Given this list of marker genes LILRA2, LGR4, BCL2, NINJ1, PTPN22, NFKBID, ZCCHC3, REG3G, NLRP2B, IFI35, GBP5, CLPB, LILRB4, GDI1, KIR2DS2, BTK, TLR4, CGAS, CD2AP, VSTM1, IFIH1, IGHG3, IRAK4, PIK3R1 (NCBI Gene Id 5295), ZAP70, RTN4, CD300A, NMI, IRF4, IGLC6, FCRL3, SLC39A10, KLHL6, BTNL2, CD274, KIR2DS3, FCHO1, EPG5, KCNN4, PTPN2, GPLD1, IRF5, TLR6, UBASH3A, IGSF1, ABL1, CRKL, BTN2A2, RBCK1, SYK, TNF, SPPL3, HSPA1A, CD47, CACNB3, COLEC11, MAVS, NFKBIA, NFATC2, CD24, OGT, CD300LB, CD28, PTPN6 (NCBI Gene Id 5777), CCR7, COLEC12, CSNK1A1, XIAP, PYDC1, MAP3K1 (mitogen-activated protein kinase kinase kinase 1), AKT1 (AKT serine/threonine kinase 1), TAX1BP1, KIR2DS4, TRIM11, ITPRIPL1, SRC, FCGR3A, CLEC7A, IRAK1, LYN, MIR34A, LAMP2, LTF, DGKZ, TLR8, DDX41, HMGB1, MNDA, EIF2B3, OSCAR, TNIP1, NOS2, ZDHHC1, BLNK, RELA, CD33, PAK2, FOXP3, NLRP1, KIR2DL4, IGHD, ELF1, SMPDL3B, SLC15A4, FOSL2, TIFA, FER, KLRC2, PAK1, CD19, LILRA6, SARM1, LAIR2, PYCARD, WASHC4, CLEC12B, PPP6C, NECTIN2, LAX1, LATS2, TYRO3, BCAR1, CD79B, CTLA4, HLA-A, LAT2, DENND1B, C5AR1, NPLOC4, MOG, LRRC19, TICAM1, CD8A, LILRB3, PRKCD, BTNL10P, EIF2AK2, CR1, FBXL2 (F-box and leucine rich repeat protein 2), AURKB, TRIM3, FPR1, STAP1, MAPK8, HDAC6, FLOT2, TRBC2, IFNG, FCGR2A, CD22, RAB7B, NLRX1, RFTN1, DUSP22, LAIR1, C3, PUM1, HLA-G, NAGK, FCER2, THEMIS, TMIGD3, DDX3X, IRGM, TLR9 (NCBI Gene Id 54106), GPR32, CYBA, MS4A1, YWHAE, TRAF6, MAPKAPK3, HSPA8, PAK3, NOD1, THY1, BTLA, HCFC2, KIR2DL3, PUM2, LIMK1, PIGR, KIR3DX1 (NCBI Gene Id 90011), CD226, CD247, NFKB1, TRAF3, ERMAP, RNF144A, BANK1, LILRA5, VAV1, NLRP3, LILRA1, NR1H3, TRGC1, MARCHF5, APP, MAP3K7, MAPK10, FCN1, KLRC4-KLRK1, TKFC, SPSB3, DHX33, IGHA2, KLRD1, NLRC4, IL20RB, BTN3A1, BRAF, ELP6, CD72, ESR1, KLRK1 (NCBI Gene Id 22914), VAV3, TLR1, TLR3, RNF170, TIRAP (TIR domain containing adaptor protein), KIR2DL5B, IRF3 (interferon regulatory factor 3), TLR10, P2RX7, NLRC3, LRRC14, KLRC1, BTN2A1, GCSAML, TLR7, FCMR, TRGC2, KIR3DL1, PSEN1, BTNL9, IRF1, APPL2, FCGR1BP, FGR, GKN2, FCGR1A, SH2B2, PRKCQ, ZNRF1, SPG21 (SPG21 abhydrolase domain containing, maspardin), BIRC3, MYD88 (NCBI Gene Id 4615), BPIFB1, KIR2DL1, MARK4, TREX1, CLEC4D, MIR146A, TNFAIP3, FCN2, MIR149, PLD2, LILRA3, MEF2C, SCARA3, GPR33, MIR17, DHX58, FCER1G, NEK7, PLCG2, PLA2G6, DAB2IP, TLR2, KIR2DL5A, ZC3H12A, HSPA1B, LIPA, LRCH4, IRAK2, BTNL8, ATAT1, TRIM31 (tripartite motif containing 31), S100A8, MAPK1, LIME1, PCBP2, RNF31, NOP53, A1BG, KIR3DL3, SOS1, NCKAP1L, CPTP, TYROBP, SCIMP, RSAD2, IGKC, CCDC134, OAS3, IGHG1 (immunoglobulin heavy constant gamma 1 (G1m marker)), CD79A, LILRB2, CD8B, PRKCE, FCGR3B, RIGI, KIR3DL2, RABGEF1, PTPRS, PRKD2, S100A14, FCAR, TASL, LGALS3, CARD11, HCK, GPS2, IKBKB, HSP90B1, TEC, CD36, CD276, PDE4B (NCBI Gene Id 5142), PLCL2, S100A9, RIPK2, UBR2, EIF2B2, MIR200B, RNF125, TRIM25, CACNB4, C5AR2, ANKRD17, PHPT1, PLSCR1, NAIP, UFD1, NR4A3, PPP2CA, TBK1, MAP2K4, MYO1G, OASL, LSM14A, TRIL, ITCH, BMX, UBE2N, PRNP, SKAP1, KCNK13, NCR3, RGCC, KLRC4, MIR20A, BANF1, MIR210, KIT, EP300, TRIM32, FLOT1, UNC93B1, LAPTM5, HLA-DRB3 (major histocompatibility complex, class II, DR beta 3), IRAK3, CD200R1, ZDHHC5, KIR2DS1, SMPDL3A, TMEM126A, FCGR2C, SEC14L1, LILRB1, PTK2, RAP1A (RAP1A, member of RAS oncogene family), TESPA1, WDFY1, GCSAM, RAB29 (NCBI Gene Id 8934), RC3H2, STMP1, MIR18A, PELI1, OAS1, HLA-DRB1, ABHD8, CD300LF, MEFV, RNF34, LCP2, C1QBP, INAVA, CEACAM1, MIR140, USP15, PDPK1, STK11, LILRA4, CD38, CACTIN, FYB1, ZDHHC18, GPR32P1, ZC3HAV1, NR1H4, PARP1, NFKBIZ, FFAR2 (free fatty acid receptor 2), STOML2, KIR3DS1 (NCBI Gene Id 3813), BIRC2, GRAMD4, SLC15A2, MALT1, DDX60, DUSP3, TNFRSF21, IGHG2, IKBKG, WNK1 (NCBI Gene Id 9872), KIR2DL2, PLPP4, F2RL1, PRKCB, AIM2, KHDRBS1, PYDC2, GP6, RNF39, ALPK1, EZR, BTN1A1, C3AR1, KCNK6, TRAT1, IGHA1, IGLC7, ITK, MBL2, ARRB2, AP3B1, PHB2, EIF2B5, PRKD1, INPP5D, HAVCR2 (NCBI Gene Id 84868), VAV2, SLA2, FPR2, TRBC1, BTN3A3, COLEC10, KCNJ8, CD300LD, LGALS9, BRCC3, IGLC3, MFHAS1, ABHD17A, PTPRJ, LCK, CLEC4E, BAG6, NFAM1, PLEKHA1, ZDHHC12, LBP, SLC46A2, ZDHHC9, CD160, CTSH, FYB2, TRIM15, LYPLAL1, CD40, CASP1, TLR5, CREBBP, CYLD, PPT1, CD3G, CTSS, PSG9, LETMD1, PHB1, NAGLU, SLC39A6, CD14, TRAC, TXK, SLC19A1, MIR4691, TNIP3 (NCBI Gene Id 79931), FOXP1, NCK1, PIK3AP1, HRAS, HHLA2, PDE4D, SHB, NFKBIL1, IGHG4, MAP2K6, IRF7, EIF2B4, SIVA1, HLA-DPB1, THEMIS2, MIR19A, TREML4, IGHM (NCBI Gene Id 3507), PLCG1, GBP2, GFI1, ZNF683, GATA3, BCL10, PJA2, CD3D, ACOD1, UBQLN1, PIK3CA, TRDC, CLEC6A, HSPD1, RNF115, RNF135, OTULIN, LACC1, SLC15A3, CD3E, PVRIG, TRIM65, LATS1, TREM2, MAPK9, YES1, ADA, ERBIN, CSK, TARBP2, NLRP6, TNIP2, FCN3, ZNRF4 (NCBI Gene Id 148066), SQSTM1, TIFAB, KIR2DS5, MIR708, PTPRC, CMTM3, TAB1, LILRB5, NOD2, PRKDC, FOSL1, PIK3CD, CHUK, GPR108, IPO5, NR1D1, LPXN, GPATCH3, MAPKAPK2, MAP2K7, IFI16, AARS2, PYDC5, TRAF3IP3, GRB2, FCGR2B, SIRT2, PAWR, CARD8, ECSIT, IGLC1, TSPAN6, BAX, TICAM2, BTRC, FYN, USP17L2, PRKCH, KLRC3, GBP1, ITGAM, MIR200C, FCER1A, BECN1, APPL1, FPR3, CD81, BTNL3, CBLB, IGHE, CMKLR1, HLA-DQB1, BTN3A2, SH2D1A, USP50, MICB, EIF2B1, RC3H1, RPS6KA3, NCR1, PRAM1, TARM1, CAV1, STING1, LY96, BTN2A3P, LAT, RPS3, CR2, BLK, RAB11FIP2, OTUD4, ZDHHC3, RIOK3, ICOSLG, VTCN1, here is a description of the gene set: Human Gene Set: GOBP_IMMUNE_RESPONSE_REGULATING_SIGNALING_PATHWAY species: Homo sapiens The cascade of processes by which a signal interacts with a receptor, causing a change in the level or activity of a second messenger or other downstream target, and ultimately leading to the activation, perpetuation, or inhibition of an immune response.